Given this list of marker genes HDAC1, SNAI1, RHEB, RBBP4, PPARG, JUN, LAMTOR2, SCMH1, ATF2, NR2E1, HDAC3, RNF2, MAF1, SLC38A9, MECOM, EGR1, HDAC2 (histone deacetylase 2), REST, MAPK1, TP53, MTA1 (metastasis associated 1), LAMTOR5, EED, CBX2, ATN1, KDM1A (lysine demethylase 1A), MTA2, RBBP7, PTEN, LAMTOR3, LAMTOR1, BMI1, PHC2, MTA3, RCOR1, RRAGC, CBX4, GATAD2A, RRAGA, RPTOR, GATAD2B, LAMTOR4, MAPK3, EZH2, RRAGB, HDAC7, MTOR, CBX8, RRAGD, RING1, PHC1, CBX6, MBD3, MLST8, CHD3, SALL4 (NCBI Gene Id 57167), HDAC5, CHD4, SUZ12, SNAI2, PHC3, here is a description of the gene set: Human Gene Set: REACTOME_REGULATION_OF_PTEN_GENE_TRANSCRIPTION species: Homo sapiens Regulation of PTEN gene transcription